The following is a description of a gene set: studied in species Homo sapiens Genes predicted to be targets of miRBase v22 microRNA hsa-let-7d-3p in miRDB v6.0 with MirTarget v4 prediction scores > 80 (high confidence targets). Human Gene Set: LET_7D_3P from publication Chen Y, Wang X (PMID 31504780), and this is the list of marker genes: GSTK1, PTGIS, MEX3C, PRKACB, HMGA2, PARP11, SH3RF1, BEND2, SEC24D